The following is a description of a gene set: Mouse Gene Set: CUI_T_CELL_GD_BAFF_RESPONSE_DN Genes negatively differentially expressed in cell type: γδ T cell upon treatment with cytokine: BAFF in mouse lymph nodes in vivo. studied in species Mus musculus from publication Cui A, Huang T, Li S, Ma A, Pérez JL, Sander C, Keskin DB, Wu CJ, Fraenkel E, Hacohen N (PMID 38057668) Cytokines mediate cell-cell communication in the immune system and represent important therapeutic targets. A myriad of studies have highlighted their central role in immune function, yet we lack a global view of the cellular responses of each immune cell type to each cytokine. To address this gap, the authors created the Immune Dictionary, a compendium of single-cell transcriptomic profiles of more than 17 immune cell types in response to each of 86 cytokines (>1,400 cytokine-cell type combinations) in mouse lymph nodes in vivo. A cytokine-centric view of the dictionary revealed that most cytokines induce highly cell-type-specific responses. For example, the inflammatory cytokine interleukin-1β induces distinct gene programmes in almost every cell type. A cell-type-centric view of the dictionary identified more than 66 cytokine-driven cellular polarization states across immune cell types, including previously uncharacterized states such as an interleukin-18-induced polyfunctional natural killer cell state., and this is the list of marker genes: Fosb, Hspa1a, Nt5e, Hspa1b, Klf6, Jund, Rgs2, Fos, Nfkbiz, Ier2, Ppp1r15a, Junb, Cd69, Coq10b, Ramp1, Neat1, Dusp1, Jun, Rgs1, Rhob, Dnaja1, Btg2, Tob2, Zfp36, Emb, Ubc, Nr4a1, Klf2, Cebpb